Given this list of marker genes COL1A1, LFNG, NEDD4L, PLOD3, RPL10, here is a description of the gene set: Human Gene Set: HP_FLEXION_CONTRACTURE_OF_THE_2ND_FINGER studied in species Homo sapiens Chronic loss of joint motion in the 2nd finger due to structural changes in non-bony tissue. The term camptodactyly of the 2nd finger is used if the distal and/or proximal interphalangeal joints are affected. Flexion contracture of the 2nd finger